The following is a description of a gene set: studied in species Homo sapiens Abnormality of vascular function. Abnormal vascular physiology Human Gene Set: HP_ABNORMAL_VASCULAR_PHYSIOLOGY, and this is the list of marker genes: ACTA2, FCGR2B, MFAP5, CLCN7, COLQ, HLA-DPB1, SLC29A3, ENG, PSMB9, TREX1, SLC2A10, BRAF, DLL4, FOXE3, MT-CO1, BLK, ACTB, TNFAIP3, IL12A, TLR4, SCNN1B, SARS2, KCNN4 (NCBI Gene Id 3783), PLOD1, AFF4, KCNK3, MMACHC, NPPA, AGGF1, CCR1, ATP13A3, JAK2, AGXT, TLR7, LIMK1, SAT1, MEG3, TLL1, TERC, CR2 (NCBI Gene Id 1380), CDH23, ELN, RYR1, USP48, BMP6 (bone morphogenetic protein 6), SFTPB, GNAQ, MT-ND6, NAGS, UBAC2, SEC61A1, BMPR2, ERI1, RNASEH2C, SFTPA2, MAT2A (NCBI Gene Id 4144), LARS2, TBL2, COQ2, RPL3L, PLOD3, SLC34A2, PXK, NOD2 (nucleotide binding oligomerization domain containing 2), CTLA4 (cytotoxic T-lymphocyte associated protein 4), IL12A-AS1, IDUA, TNFSF11, HLA-B, VHL, TERT, MT-ND1, C4B, XYLT1, AGK, PIK3CA, F8, ABCD4, STING1, BAZ1B, ZNF699, COL4A1, MYH6, MED25, IRF5, KIAA0319L, SLC25A24, CLCNKB, ABCA3, ITGAM, TP53, RNU7-1, MYBPC3, GTF2I, GNB2, CAV1, LCK, C4A, THPO, MPL, IPO8, BRCC3, FOXP1, TGFBR3, PAM16, LBR, COL1A2, COL1A1, TBX4, CLIP2, DLK1, NR3C1, IL23R, SLC12A3, CLXN, NCF1, UBE2L3, EOGT, IL6, STAT4, PTPN22, HTRA1 (NCBI Gene Id 5654), LIPT1, TBX20, FLNA, FSHR, SH2B3, FKBP14, EIF2AK4, IRAK1, LMNA, CACNA1C, GBA1, TBX5, ETS1, TNNI3, LAMA2, ADAR, MT-CO3, ADAMTS13, ACTC1, TGFBR2, CACNA1D, LOX, ZMPSTE24, SMAD9, HRAS, ALMS1, RNASEH2A, XPNPEP2 (X-prolyl aminopeptidase 2), TINF2, APP, TMEM270, MT-TF, FKBP6, ARHGAP31, GLA, FBN1, SAMHD1, RNF213, FCGR3B, ARSB, NAA10, JAZF1, HLA-DRB1, COX7B, THSD4, HFE, MECP2, BANF1, NDUFB10, AGR2, SCARB2, ANGPTL6, F5, NKX2-1, TRRAP, HBB, CD55, PGM1, COX6B1, NT5E, RNF125, ATRX, TCIRG1, UBE2A, MT-TL1, TGFBR1, CALR, F2, ACP5, PIGN, NAGA, IFT56, IFNGR1, SLC37A4, GUCY1A1, EFEMP2, ADA2, MYH7, KRT18, STAT1, PPCS, VCL, ATP5F1A, BTNL2, COLGALT1, KCNJ5, IL10, CCN2, ODAD1, SCN5A, MT-TS2, RHAG, MGP, NFIX, VPS33A, MT-TQ, IKBKG, SLC4A1, GTF2IRD1, GATA6, SOX9, COX8A, NF1, TNFSF4, LACC1, NKX2-5, CAPNS1, FGFR3, PDSS1, FAS, COG1, PLP1, PRKG1, MED12, KDM6A, HSPG2 (NCBI Gene Id 7796), CBS, IL6ST (interleukin 6 cytokine family signal transducer), VPS37D, ACTG1, SMARCAL1, HEY2, FIG4, CITED2, CCR6, IL12B, ALDH1A2, AEBP1, PROC, ADAMTSL2, FBXL4, DEF6, CTNNB1, F13A1, THSD1, SNX10, RNASEH2B, MUC5B, RTL1, TET2, CA2, SMAD2, NDUFA8, NOTCH3, COL5A1, SAA1, COL3A1, APOLD1, IFIH1, SPP1, COL5A2, LIFR, PRTN3, SERPINC1, P4HA2, PIGA, ANO1, HLA-DPA1, GTF2IRD2, STX1A, FGFR1, MT-ND5, MT-TW, MTHFR, NOTCH1, PIEZO1, ACVRL1, METTL27, EIF4H, GATA4, RFC2, AKT1, HABP2, MYLK, BUD23, MYPN, DNAJC30, ABCC6, GDF2, FOXF1, PRDX1, COX5A, MT-ND4, FLNC, KRAS, TGFB2, SMAD3, MYH11, DNASE1, G6PC3, SFTPC, TNNT2 (troponin T2, cardiac type), XYLT2, SMAD4, SCNN1G, PDCD1, ALB, LSM11, IGHG1, USP8, SCNN1A, TNIP1, TGFB3, DOCK6, MLX, VAC14, KMT2D, PRIM1, KIF20A, KLRC4, PIK3C2A, PROS1 (NCBI Gene Id 5627), MEFV, LAMB2, THBD, MT-TH, BANK1, EPHB4, ENPP1, SON, RBPJ, NFU1, MIF, MT-CO2, ERAP1, RASA1, CTCF, MYMK, CHST3